The following is a description of a gene set: species: Homo sapiens The assembly and organization of the sperm flagellum, the microtubule-based axoneme and associated structures that are part of a sperm flagellum (or cilium). Human Gene Set: GOBP_SPERM_FLAGELLUM_ASSEMBLY, and this is the list of marker genes: CFAP44, DRC7, LRRC46, CFAP43, CFAP119, CFAP221 (NCBI Gene Id 200373), CFAP57, GK2, SPEF2, BBOF1, IFT81, CFAP206, BBS2, VDAC3, ARMC2, CFAP65, ARMC12, RSPH6A, AKAP4 (NCBI Gene Id 8852), TTLL5, DNALI1, SPAG6, KLC3, CFAP58, PLA2G3, CFAP157, YIF1B, CFAP69, ZMYND12, CFAP53, CFAP47, FSIP2 (fibrous sheath interacting protein 2), SPAG16, NEURL1, MEIG1, DNHD1, DNAH1, CCDC159, CFAP61, CFAP97D1 (NCBI Gene Id 284067), CCDC38, CFAP54, TTC12, IQCG, TTLL1, CCDC146, CEP131, CEP128, UBE2B, POC1B, DRC1, TPGS1, DZIP1, PDCL2, TBC1D21, PFN4, BBS4, MNS1